The following is a description of a gene set: part of: Diseases of hemostasis studied in species Homo sapiens This module also describes elevation of FIX, FV activities associated with thrombophilia. Genetic variants are named following Human Genome Variation Society (HGVS) nomenclature with sequence numbering starting from the first methionine of the protein as +1 (Goodeve AC et al.2011). Reactome Pathway: Defects of Coagulation cascade, and this is the list of marker genes: GGCX, F11, GP9, F2, ANO6, PROC, F9, FGB, GP1BA, F8, F5, PROS1, TPST2, VWF, F10, FGA, GP5 (glycoprotein V platelet), GP1BB, APP, FGG, TPST1